The following is a description of a gene set: Pathway Definition from KEGG: E2 -> ESR1/2 -> SRC -> RAS -> RAF -> MEK -> ERK -> (ESR1/2,AP1) => CHRNA9 studied in species Homo sapiens Human Gene Set: KEGG_MEDICUS_ENV_FACTOR_E2_TO_RAS_ERK_SIGNALING_PATHWAY E2 to RAS-ERK signaling pathway. Pathway ID: N01353. Pathway type: Env factor. Pathway class: nt06210 ERK signaling., and this is the list of marker genes: ARAF, MAPK3, NRAS, ESR2, FOS, ESR1, MAPK1, SRC, KRAS, RAF1, JUN, MAP2K1, HRAS, MAP2K2 (NCBI Gene Id 85511), BRAF, CHRNA9